Given this list of marker genes GAS6, CHD8, PIK3CA, API5, MIR24-1, CFDP1, SFRP1, PIK3CG, here is a description of the gene set: Any process that stops, prevents or reduces the frequency, rate or extent of fibroblast apoptotic process. species: Homo sapiens Human Gene Set: GOBP_NEGATIVE_REGULATION_OF_FIBROBLAST_APOPTOTIC_PROCESS